Given this list of marker genes DHFR, FTCD, CD320, FASN, CUBN, MMACHC, C8G, MMUT, RBP5, P3H3 (NCBI Gene Id 10536), OGDH, ALAS2, RBP3, PDXK, PDXDC1, GPT, UROS, GAD2, SHMT1, GOT1, GGCX, TKTL1, TTPA, GOT1L1, P3H2, THNSL2, OGDHL, PHYKPL, OPN3, SCLY, GCAT, RBP2, OGFOD3 (NCBI Gene Id 79701), KL, ACCS, DHTKD1, TAT, GNMT, CBS, NPC1L1, ILVBL, CTH, RLBP1, AADAT, FOLR3, HLCS, IZUMO1R, AFM, PCCA, CYP27C1, ALKBH3, GAD1, AGXT, P4HTM, CYP2W1, NFS1, FTCDNL1, MTARC1, RHO, ENSG00000274276, CRABP2, DDC, AGXT2, CSAD, P4HA1, STRA6 (NCBI Gene Id 64220), GLDC (NCBI Gene Id 2731), MCCC1, DHFRP1, ABCA4, GPT2, GOT2, SHMT2, ACACB, PYGB, PLOD3 (NCBI Gene Id 8985), HACL1, PC, KYAT3, TPK1, P3H1, PDXDC2P-NPIPB14P (PDXDC2P-NPIPB14P readthrough, transcribed pseudogene), TCN2, OPN5, P4HA3, CISD1, MTHFS, ALDH1A2, LMBRD1, ALB, MOCOS, PSAT1, OPN4, ACCSL (NCBI Gene Id 390110), PYGL, HDC, FOLR2, ADH7, DBH, CYP2R1, OAT, PANK3, SLC19A1, P4HA2, KYAT1, TKTL2, ADH4, MMAB, SDSL, VDR, TCN1, CBLIF, PNPO, EGLN3, PYGM, OGFOD2, SPTLC1, TKT, ABAT, RBP1, MTR, CALB1, OGFOD1, SLC46A1, MTARC2, SPTLC2 (NCBI Gene Id 9517), GADL1, TYMS, SEC14L2, RBP7, S100G, LRAT, EGLN1, PLOD1, CRABP1, EGLN2, RBP4, GC, ALAS1, SDS, SPTLC3, SGPL1, PHYH, ETNPPL, FOLR1, PLOD2, PAM, PLPBP, KYNU, IRX5, SRR, here is a description of the gene set: species: Homo sapiens Binding to a vitamin, one of a number of unrelated organic substances that occur in many foods in small amounts and that are necessary in trace amounts for the normal metabolic functioning of the body. Human Gene Set: GOMF_VITAMIN_BINDING